The following is a description of a gene set: Human Gene Set: REACTOME_MET_PROMOTES_CELL_MOTILITY species: Homo sapiens MET promotes cell motility, and this is the list of marker genes: LAMA3, LAMA1, GRB2, RAPGEF1, COL1A2, LAMB2, COL5A2, COL24A1, DOCK7, ITGA2, COL1A1, COL3A1, COL5A1, COL11A2, ITGA3, ITGB1, PTK2, COL2A1, LAMB3 (NCBI Gene Id 3914), LAMC1, TNS4, COL27A1, LAMA5, RAP1B, MET, COL11A1, LAMB1, TNS3, RAP1A, LAMC3, RAC1, LAMA2, CRKL, COL5A3, CRK (CRK proto-oncogene, adaptor protein), FN1, HGF, GAB1, LAMA4, SRC, LAMC2